Given this list of marker genes Arl4c, Ptprcap, Tut7, Gnat2, Fkbp5, Polrmt, Hcfc1, C1qtnf12, S100a11, Pkp2, Aldh1a7, Lpin2, Tcea1, Rabggtb, Tlcd4, Il1rl1, H3f3b, Cul2, Nptx1, Cep89, Mapk8, Scnm1, Map3k7, Dtd1, Sowaha, Slc19a1, Aplp2, Ifi205, Gna15, Acss1, Rcc1, Lxn (NCBI Gene Id 17035), Bcat2, Eloc, Spryd7, Lpin1, Slc4a1, Taf1d, Gfi1b, Desi1, Cmpk2, Crem, Ppox, here is a description of the gene set: We mapped quantitative trait loci that accounted for the variation in hematopoietic stem cell (HSC) numbers between young adult C57BL/6 (B6) and DBA/2 (D2) mice. In reciprocal chromosome 3 congenic mice, introgressed D2 alleles increased HSC numbers owing to enhanced proliferation and self-renewal and reduced apoptosis, whereas B6 alleles had the opposite effects. Using oligonucleotide arrays, real-time PCR and protein blots, we identified latexin (Lxn), a gene whose differential transcription and expression was associated with the allelic differences. Expression was inversely correlated with the number of HSCs; therefore, ectopic expression of Lxn using a retroviral vector decreased stem cell population size. We identified clusters of SNPs upstream of the Lxn transcriptional start site, at least two of which are associated with potential binding sites for transcription factors regulating stem cells. Thus, promoter polymorphisms between the B6 and D2 alleles may affect Lxn gene expression and consequently influence the population size of hematopoietic stem cells. Mouse Gene Set: LIANG_HEMATOPOIESIS_STEM_CELL_NUMBER_LARGE_VS_TINY_DN from publication Liang Y, Jansen M, Aronow B, Geiger H, Van Zant G (PMID 17220891) species: Mus musculus Genes down-regulated in LSK cells (bone marrow) as a function of a QTL for the size of hematopoietic stem cell (HSC) population: comparison of congenic B.D. chr3 (BD, large HSC size) vs parental B6 strain (tiny HSC size).